The following is a description of a gene set: Genes up-regulated in germinal center B lymphocytes over-expressing: PRDM1 versus Epstein-Barr virus protein LMP1. In this study, we have investigated the effect of BLIMP1α on gene expression, cell differentiation and pathogenesis in normal human GC B cells using a non-viral vector based system from publication Vrzalikova K, Vockerodt M, Leonard S, Bell A, Wei W, Schrader A, Wright KL, Kube D, Rowe M, Woodman CB, Murray PG (PMID 21411757) studied in species Homo sapiens Human Gene Set: GSE27670_BLIMP1_VS_LMP1_TRANSDUCED_GC_BCELL_UP, and this is the list of marker genes: ZNF518B, STX2, ACP5, TBX6, CHRND, CXADR, HYOU1, SETD3 (SET domain containing 3, actin N3(tau)-histidine methyltransferase), ITGB2, ITSN1, HAS3, ITGB5, APOC4, CD79B, ERBB3, TYROBP, LY9, APOC1, PLOD3, BLNK, MSH6, MATN1, BATF, PML, SIAH2, PRKCG, SKA2, SHISA5, DNMT3A, ADGRG3, ACSS1, NRP1, DRD3, ADCY7, IFI27L2, APOC2, RXRA, CERK (NCBI Gene Id 64781), APRT, ATP1B1, PLEKHO1, HLX, SSR2, ZBTB7B, LECT2, TPRA1, CSF3R, RAB3IL1, GRN, LAPTM5, STAB1, C9, ENPP1, TEN1 (TEN1 subunit of CST complex), FAM89B, C2, HCK, CYBC1, KCNH1, PPP1R21, GBA1, PNMT, GSTM3, KRT71, PDE4DIP, USP2, CMA1, DDOST, MYO1F, PPFIA4 (NCBI Gene Id 8497), MTHFR, POU2F2, GLI1, PIK3CD, FOXD4L1, RAI1, COX7A1, IDH2, FES, ETFB, GMIP, ABR, NAA40, HCLS1, CSF1R, SIRPA, TOM1, EEPD1, F8A1, SLC3A2, STARD3, TSPAN4, EDEM2, GP9, MAGEB4, KCNQ2, BCL2L10, HPCAL1, PHF23, NR1H2, TLR7 (NCBI Gene Id 51284), GPRASP1, SIRT2, PLD4, LY86, EDN1, HPN, FBXW4, GUSB, SRPX, ST6GALNAC4, EIF4A1, FLT3, COL6A3, POR, ABCC5, PLAUR, NNT, IGSF8, GNA12, TENT5C, CORO1B, PSAP, RPS6KA4, CD48, COPRS, BMP15, PITPNA, PLD2, MPEG1, TEP1, SLC34A1, HMBOX1, FNBP1, BATF3, GSTO1, C16orf74, DCPS, RNF26, KLC2 (kinesin light chain 2), CDR2, ARF3, HASPIN, SLC27A4, PLCG2, GNS, PLBD1, FCGR1A, TSC2, POU3F1, CERS2, MEP1B, SRPK3, RGL1, PAPOLB, GUCA1A, CTSH, TUB, PVALB, STXBP2, ATG7 (autophagy related 7), ACP2, EGR2 (NCBI Gene Id 1959), SLC7A7, LIPA, CLEC4D, GSTK1, AXL (NCBI Gene Id 558), CYBB, SCARB1, ADISSP, IFITM10, RAB3B, ST6GALNAC2, PCK2, HMGCL, SLC52A2, NMUR1, ZNFX1, GRPR, ELP5, NCKAP1L, ICAM5, RASA4 (RAS p21 protein activator 4), AP1G2, NUDT9 (nudix hydrolase 9), NAGLU, CPNE6, PIP4K2A, CCL2, IRF5, TFEB, SETDB1 (NCBI Gene Id 9869), COTL1, BEX4, TMED3, TLR6, BOLA2, HBEGF, COL11A2